The following is a description of a gene set: species: Mus musculus Any process that stops, prevents or reduces the rate or extent of growth, the increase in size or mass of all or part of an organism. Mouse Gene Set: GOBP_NEGATIVE_REGULATION_OF_GROWTH, and this is the list of marker genes: Ppp1r9b, Eno1b, Cirbp, Tgfb1 (NCBI Gene Id 21803), Ing5, Foxp1, Bdkrb1, Rgs2, Nog, Men1, Ifrd1, Tnr, Ccdc85b, St7l, Dnajb2, G6pdx, D130043K22Rik, Cxadr, Osgin2, Pi16, Zmat3 (zinc finger matrin type 3), Eno1, Hif1a, Hspa1a, Smad3, Sesn1, Gja1, Fbp1, Myoz1, Rgma, Kcnk2, Ei24, Spag9, Ahsg, Sertad1, Sema3a, Yy1, Pnpt1, Sema4f, Hdac2, Gpc3, Sema3g, Bmp10, Msx1, Rgs4, Ptk6, Hnf4a, Mag, Ndufa13, Dspp, Dnajc2 (DnaJ heat shock protein family (Hsp40) member C2), Sh3bp4, Vgll4, Tmem196, Sox17, Wnt11, Alms1, Spart, Mt3, Ntn1, Tnk1, Dip2b, Map2, Dab2ip, Serpine2, Bbc3, Rrad, Lgmn, Tchp (NCBI Gene Id 77832), Naif1, Cth, Gnas, Ip6k2, Ppt1, Slit3, Hyal1, Ankrd26, Sphk2, Hyal2, Ptch1, Adipor2, Gdf2, Ostn, Sfrp1, Sema6d, Rnf6, Ptprj, Gng4, Ulk2, Mul1, Nppa, Trp73, Tspyl2, Stc2, Tbx5, Gas1, Fstl4, Dcun1d3, Mecp2, Cyp27b1, Cdkn2a, Hspa1b, Cdkn2d, Atxn2, Fgf13, Cav3, Cgref1, Dact3, Atg16l1, Ing4, Enpp1, Zc3h12d, Mstn, Cga, Rbbp7, Wwc1, Hrg, Sfrp2, Wwc2, Cdhr2, Nme6, Cda, Slit1, Igfbp5, Draxin, Bmpr2, Ppard, Sema6c, Minar1, Adrb2, Psrc1, Stk4, Fxn, Sesn2, Gdf9, Tcf7l2, G6pd2, Ttc3 (tetratricopeptide repeat domain 3), Ccr5, Sertad2, Dcstamp, Crlf3, Bbs2, Bcl6, Smarca2, Tll2 (tolloid-like 2), Slc6a4, P3h1, Bst2, Osgin1 (oxidative stress induced growth inhibitor 1), Wnt5a, Pten, Adrb1, Cryab, Wt1, Sav1, Plac8, Ccar2, Trim46, Cdkl3, Stk11 (serine/threonine kinase 11), Inhba (inhibin beta-A), Acvr1b, Sema5a, Pak1, Cdkn1b, D1Pas1, Ppara, Mt2, H19, Adam15, Rai1, Adipor1, Rbm10, Trim40, Nppb, Cfl1, Slit2, Fgfr3, Ndufs3, Mir1a-2, Ulk1 (NCBI Gene Id 22241), Fhl1, Caprin2, Rb1, Rtn4r, Ddx3x, Pparg, Rack1, Gdf15, Smarca4, Bcl2, Trp53, Cdkn2c, Hdac6, Ccn3, Myl2, Mt1, Rtn4 (NCBI Gene Id 68585), Agt, Acvrl1 (activin A receptor, type II-like 1), Cdkn1a, Frzb, Cdh1, Wnt3a, Grem1 (gremlin 1, DAN family BMP antagonist), Alox8, Zfp418, Nrp1, Sema3f, Prdm4, D7Ertd443e, Ryk, Rerg, Actr3, Foxk1, Tgfbr2, Prdm11, Dusp10, Adrb3, Arhgap4, Dcbld2, Tgfb2, Sertad3, Ctdp1, Cdk5, Rbp4, Eaf2, Tomm70a, Tmprss4, Pml, Bcl11a, Wnt3, Brca1, Phb1, Mapk11, Tro, Dab2, Jarid2, Epha7, Cdkn2aip, Gsk3b, Ptk2 (NCBI Gene Id 14083), Cited2, Ptprs, Nf2 (neurofibromin 2), Apc, Mndal, Plxna3, Socs2, Gsk3a, Stk3, Smad4 (NCBI Gene Id 28063), Cgrrf1